The following is a description of a gene set: Human Gene Set: HP_ABNORMALITY_OF_URINE_HOMEOSTASIS species: Homo sapiens Abnormality of urine homeostasis An abnormality of the composition of urine or the levels of its components., and this is the list of marker genes: PGAM2, NAGA, AP2S1, POU6F2, HNF1B, ITGAM, DDC, CACNA1S, FGF23, CLDN19, NFU1, MAX, ATIC (NCBI Gene Id 471), TRIP13, MUC1, MIA3, COQ2, SFXN4, HELLPAR, PIK3CA, COL4A4, CYP11A1, NR0B1 (nuclear receptor subfamily 0 group B member 1), MC2R, ABCC8, LDHA, MCEE, KCNJ11 (potassium inwardly rectifying channel subfamily J member 11), INPPL1, CBS, LCAT, PGK1, SH2B1, TAFAZZIN, ELN, ALDOA, UPB1, STAT2, SLC25A4, LYZ, PLOD1, C4A, SLC35C1 (solute carrier family 35 member C1), MAFB, DNASE1L3, MAGED2, CPT1A, KCNJ18, UROD, SDHB, GCLC, CLCN5, SLCO2A1, COL2A1, ECHS1, DGUOK, SERPINF2, GSS, TNFAIP3, PLOD2, TKT, PDP1, TREX1, GTF2I, GALNS, TRAF3IP2, ZNRF3, SEC61A1, EPAS1, MT-TK, CTLA4, ADA2, PIGA, P4HA2, AVPR2, H19, IL1B, DHTKD1, GK, KCNJ1, GATA1, TERT, KYNU, PHKB, HNF4A, UQCRB, ALG9, MMUT, NIPBL, SLC2A9, SLC12A1, GNA11, AKR1D1, FKRP, SARS2, ACADSB, DPYS, FCGR2A, COQ8B, MT-TV, WDR19, KRT18, MTX2, GSN, DDOST, STX16, PBX1, FCGR3B, ADCY10, NDUFAF6 (NCBI Gene Id 137682), ETS1, PXK, SLC52A2 (solute carrier family 52 member 2), CFTR, CASK, THBD (thrombomodulin), MT-ND5, SLC26A1, SMARCAL1, LMO1, AUH, ARSB, ASS1, MT-TL1, FCGR2B, ASPH, SUCLG1, TLR7, ACADVL, CAMKMT, TNFSF4, PTPRO, MT-ND4, SHPK, GP9, DLST, MCCC2, CLCNKB, SLC18A2, FGFR2, NPHS1, AGGF1, SPINK5 (NCBI Gene Id 50962), MT-TH, FBXL4, PHKG2 (phosphorylase kinase catalytic subunit gamma 2), PCCB, MMAB, MPV17, TAT, ATPAF2, DCDC2, DKC1, ASPA, IL1RN, COQ4, LIN28B, CYP11B2 (NCBI Gene Id 1585), CFH, PEPD, MMAA, MED12, HADH, HLA-DRB1, CD81 (NCBI Gene Id 975), L2HGDH, HOGA1 (4-hydroxy-2-oxoglutarate aldolase 1), F8, DNAJC30, GCK (glucokinase), SDHAF2, NGLY1, CR2, NEUROD1, PHKA1, NPM1, FCGR2C, FDFT1, HEXB, CD2AP, GANAB, CYP24A1, MTR, HNF1A, ACAD8, GBA1, SLC25A19, ATP5MK, SMAD4, YRDC, LAMB2, TANGO2, SDHC, APOA1, F9 (coagulation factor IX), SDHA, SLCO1B1, NFS1, HPD, MT-ND6, PCK1, GATA3, STOX1, CYP2R1, ALPL, DPYD, AQP2, ADAMTS13, TMEM270, BTNL2, DIS3L2, ETFDH, ITGB4, MRAP, STK11, GCH1 (GTP cyclohydrolase 1), CPOX, GTF2IRD2, CRPPA, NABP1, HCFC1, PDX1, BCS1L, GALE, TMEM67, MOCOS (molybdenum cofactor sulfurase), KCNJ5, CDKN1C (cyclin dependent kinase inhibitor 1C), NSMCE2, FIP1L1, TBC1D24, MLXIPL, SURF1, NHERF1, IRAK1, PET100, SLC7A9, G6PC1, NPHS2, RRM2B, IDS, NF1, MT-ND2 (mitochondrially encoded NADH:ubiquinone oxidoreductase core subunit 2), PMM2, APOL1, F5, BCKDHA, KARS1, MICOS13 (mitochondrial contact site and cristae organizing system subunit 13), SLC3A1, SKIC3, TDO2, TBL2, IFT172, COX16, SLC6A2, LMNB2, IL17RA, ATP6V1B2, EIF4H (NCBI Gene Id 94573), IVD, SLC25A1, ETHE1, ETFB, IL10, TNFRSF11B, SLC22A5, ACTN4, NUP37, PCBD1, PIGT, NPHP1, ZAP70, FOXP2, PRDX1, TRPC6, OSGEP, MT-CO3, UMPS, CFHR5, MT-TQ, REST, STAT4, ITGA2B, HGD, IL17F, STAT5B, DLG5, ITGA3, ANLN, VHL, MT-CO1, MT-CO2, ISCU, ATP6V0A4, SLC1A1, HSD17B10, ITGA8, SLC25A15, SLC34A2, SPTBN1 (spectrin beta, non-erythrocytic 1), MT-ND1, SLC13A3, CLCNKA, ENPP1, ACADM (NCBI Gene Id 51779), GON7, LMNA (NCBI Gene Id 7816), PHKA2, PAH (NCBI Gene Id 5053), CPS1, ZBTB16, GNPTG, ERBB2, CASR, KIF1B, DDB2, APRT, LPIN1, KRAS, MT-ND3, KIAA0319L, CPT2, NUP205, SLC12A3, TRPV4, NPR2, TRIM28, PREPL, GLYCTK, CLPB, SPRY2, NUP85, RMRP, MYO1E, COX14, CDC73, FGA, ERCC5, DNAJC19, TBL1XR1, G6PD, APPL1, SPP1, MOCS1, ITGA2, TP53RK, EXT2, JAZF1, CDKN1B, BICC1, TSC1, BLVRA, ATP1A1, NDUFS4, MDH2, HMGCL, GP1BB, DBH (dopamine beta-hydroxylase), C1GALT1C1, MTRR (5-methyltetrahydrofolate-homocysteine methyltransferase reductase), TEFM, REN, OPLAH, MT-ATP8 (NCBI Gene Id 4509), MT-TS2, LYRM4, DNASE1, RARA, FLT1, MUTYH, MEN1 (NCBI Gene Id 4221), CTNNB1, XPC, KCNE5, GUSB, PHKG1, POLG, SLC28A1, SGPL1, BTD, PIEZO1, HLA-DPA1, BCOR, ATP5F1E, PAX2, ARSK, RET, CYP27B1, GNAS, PEX12, COL4A6, MRPL39, SLC34A1, SCARB2, TRNT1, ACSF3, TPRKB, PFKM, AASS, BSND, FKBP6, PDCD1, TBC1D8B, CLDN16, CRB2, ACP5, TMEM126B, MAN2B1, SLC16A12, MMACHC, SGCB, TMEM127, AGXT, MANBA, ALAD, NPHP3, FUCA1, PEX14, PPM1B, FAN1, DNASE2, BAZ1B (bromodomain adjacent to zinc finger domain 1B), ALDH4A1, CTNS, RFC2, ABCC2 (ATP binding cassette subfamily C member 2), GNS, DLD, SLC2A2, MOCS2, SLC6A18, LETM1, PDSS2, DGKE, GYS2, STX1A, HPRT1 (NCBI Gene Id 3251), CTH, STAT3, ANO5, CLEC7A, GALT, TNFRSF11A, HLA-B, FARS2, MLIP, GLA, SLC34A3, GEMIN4, POLRMT, UBE2L3, SLC5A2, ASL, APOE, NUP133, NUMA1, MCFD2, RNU7-1, ITGA6, COA8, GAMT, LIPT1, ATP5F1D, OCRL, AGK, SREBF1, PYGM, KLF6, APC, CLTRN, IFT122, MTHFR, STAR (NCBI Gene Id 6770), CLDN10, SLC35A1, SERAC1, CFI, SLC6A8, TRMT5, SUGCT, OXCT1, LMX1B, UNC45A, MAGI2, FH, SLC7A7, ERCC4, MMADHC, NAGLU, NOTCH2, FXYD2, OAT, CUBN, FAM20A, GGT1, PRTN3, KLF11, PGM2L1, TNIP1, FBP1, ACVR1B, COL4A3, SLC22A12, MVK, OFD1, IGHG1, ERCC2, OXGR1, SLC25A11, CA5A, PRODH, FDX2, INF2, NDUFA9, MLYCD, GLDC, CD46, ADSL, MRPS2, NADK2, CCND1, ACSL4, NOS3, IRF2BP2, PRKAR1A, SARDH, HSPD1, HTRA2, PEX1, VIPAS39, MAF, PRPS1, BANK1, IER3IP1, ATP11C, FMO3, GLUD1, OPA3, SLC36A2, KIRREL1, IFT56, MYCN, SAA1 (serum amyloid A1), SCNN1A, SLC25A20, SLC19A2, DCXR, CDKN1A, MECP2, SUMF1, VPS50, SLCO1B3, OBSCN, VPS33B, IFT140, NOS1AP, MARS1, HMGCS2, ATP7B, AMMECR1, ARNT2, ALG5, FN1, DMD, TPK1, HADHB, PET117, LIMK1, NNT, F2 (coagulation factor II), NUP107, TCN2, CDKN2B (NCBI Gene Id 1030), ABCD4, HSD11B2, GAA, XPA, CYP11B1, PKD1 (polycystin 1, transient receptor potential channel interacting), ALDOB, COL4A5, COL4A1, KHK, LARS2, NEU1, GATM, GCDH, ACADS (NCBI Gene Id 35), PCCA, ANKFY1, NUP93, SUOX, ERCC8, KIF23, RYR1, AGXT2, MT-TN, TIMM50, HRAS, IDH2, GAPVD1 (NCBI Gene Id 26130), HACE1, ALK, LAGE3, GTF2IRD1, SCO2, KANK2, SLC5A1, GNPTAB, GNAS-AS1, HBB, DAAM2, DNAJB11, GUCY2D, ATP5F1A, CORIN, MPC1, HLCS, FOXC2, NRAS, GPC3, CD320, SLC6A20, PTH1R, ITGB3, ARHGAP24, STIM1, WDR4, ERCC6, TP53, PHEX, WT1, VPS33A, LMBRD1, DPH1, BRCA2, PLCE1, KCNJ16, SDHD, INSR, BLK, KCNJ10 (NCBI Gene Id 3766), PIK3C2A, EHHADH, VPS37D, LRPPRC, ERCC3, OTC, ARHGDIA, IDUA, ALDH6A1, TSC2, TFAM, IBA57, HLA-DPB1, ARG1, SAT1, WDR73, PKD2, PHOX2B, GLB1, SLC6A19, GPHN, FOCAD, MCCC1, SGSH, OGDH, HIBCH, MEFV, ATAD3A, FAH, UROS, TRPV6, CYP21A2, IRF5, SCO1, TMEM70, PIGB, DMP1, SUCLA2, PSTPIP1, BUD23, TXNRD2, SNAP29, PNP, PEX5, PYGL, GALK1, SLC25A13, SLC37A4, CASP10, LPIN2, CDKN2A, NUP160 (NCBI Gene Id 80116), NCF1, COQ6, GRHPR, C3, CFB, UROC1, ALDH5A1, RPIA, TGFB1, INS, METTL27, LDHD, LMAN1, TK2, HAL, CD59, SLC16A1, CYP27A1, SLC52A1, SLC25A21, CEL, GCM2, PAX4, GABRA3, CHUK, NDUFB10, NT5C3A, C4B, FTCD, SERPINA6, PHYKPL, COL6A1, CYC1, HGSNAT, MT-TF, ACAD9 (acyl-CoA dehydrogenase family member 9), DMGDH, DNMT3A (NCBI Gene Id 1788), HSD3B2, XDH, ETFA, HMOX1, MYH9, YAP1, PML, CD109, MT-ATP6, IDH1, AGA, HADHA, TRIM8, IL17RC, FLAD1, ACAT1, GP1BA, EMP2, ABCC6, GNE, SNX14, LRP2, PTPN22, AMN, IRF1, MT-TW, GATA6, CDKN2C, PPOX, UMOD, CAD, ABCB7, PUS3, D2HGDH, HMBS, TAMM41, F10, TRMU, CLIP2